Given this list of marker genes Txn1, Msrb1, Msrb2, Pcmt1, Msrb3, Msra, here is a description of the gene set: Protein repair Mouse Gene Set: REACTOME_PROTEIN_REPAIR species: Mus musculus